Given this list of marker genes ASH1L, APCS (NCBI Gene Id 325), ADORA1, NPY5R, INS, SELENOS (selenoprotein S), FCGR2B, NPY, MIR302E, IL20RB, SPN, NLRP3, GSTP1, here is a description of the gene set: Any process that stops, prevents, or reduces the frequency, rate, or extent of an acute inflammatory response. Human Gene Set: GOBP_NEGATIVE_REGULATION_OF_ACUTE_INFLAMMATORY_RESPONSE studied in species Homo sapiens